Given this list of marker genes CYBC1, NCF2, CYBA, RAC2 (Rac family small GTPase 2), LCP2, CYBB, IRF8, NCF1 (NCBI Gene Id 653844), SPPL2A, here is a description of the gene set: Human Gene Set: HP_DECREASED_NEUTROPHIL_OXIDATIVE_BURST Decreased neutrophil oxidative burst species: Homo sapiens Abnormal decrease of neutrophil oxidative burst, commonly measured through oxidation of dihydrorhodamine (DHR) using flow cytometry or through nitroblue tetrazolium test (NBT) using optical microscopy, upon stimulation with phorbol-12-myristate-13-acetate (PMA), E. coli or other ligands.